The following is a description of a gene set: species: Homo sapiens Human Gene Set: HP_PROSTATITIS Prostatitis The presence of inflammation of the prostate., and this is the list of marker genes: PRTN3, PTPN22, BTK, HLA-DPA1, CTLA4, HGD, HLA-DPB1